Given this list of marker genes RHOB, PRSS23, GNPNAT1, RHOD, CTCF, TP53I11, TAF1C, SGCB, FUT4 (fucosyltransferase 4), NDRG1, SGPL1 (NCBI Gene Id 8879), CTNND1, PDE3A, AP3B2, LCK, SLC30A5, HGF, HLA-DQA1 (NCBI Gene Id 7946), CCNL2, TAF10, ITGB8, SOX7, CEPT1, EIF3L, FLOT1, GLRX, ZNF507, CNKSR1, PDCD5, here is a description of the gene set: species: Homo sapiens from publication Kyng KJ, May A, Stevnsner T, Becker KG, Kølvrå S, Bohr VA (PMID 15897889) Human Gene Set: KYNG_ENVIRONMENTAL_STRESS_RESPONSE_NOT_BY_GAMMA_IN_OLD The accumulation of DNA damage and mutations is considered a major cause of cancer and aging. While it is known that DNA damage can affect changes in gene expression, transcriptional regulation after DNA damage is poorly understood. We characterized the expression of genes in human primary fibroblasts after exposure to three different kinds of cellular stress that introduces DNA damage: 4-nitroquinoline-1-oxide (4NQO), gamma-irradiation, or UV-irradiation. Each type of stress elicited damage specific gene expression changes of up to 10-fold. A total of genes had similar changes in expression of 3-40-fold after all three kinds of stress. We examined transcription in cells from young and old individuals and from patients with Werner syndrome (WS), a segmental progeroid condition with a high incidence of cancer, and found various age-associated transcriptional changes depending upon the type of cellular stress. Compared to young individuals, both WS and old individuals had similarly aberrant transcriptional responses to gamma- and UV-irradiation, suggesting a role for Werner protein in stress-induced gene expression. Our results suggest that aberrant DNA damage-induced gene regulation may contribute to the aging process and the premature aging in WS. Human environmental stress response (H-ESR) genes not changed in primary fibroblasts from old donors in response to gamma radiation.